The following is a description of a gene set: Any process that modulates the frequency, rate or extent of post-translational protein modification. Mouse Gene Set: GOBP_REGULATION_OF_POST_TRANSLATIONAL_PROTEIN_MODIFICATION species: Mus musculus, and this is the list of marker genes: Caml, Otud4, Birc7, Nxn, Herpud1, Rpl5, Tspyl5, Ube2v1, Trib2, Rnf180, Ube2n, Mtbp, Atg7, Akt1, Isg15, Bex1, Nod2, Egr1, Arnt, Birc5, Ube2v2, Mastl, Cblb, Dtx3l, Cdc20, Cep78, Pabpn1l, Per2, Angpt1, Commd1, Itch, Amer1, Dcun1d2, Pink1, Bex3, Peli3, Wbp1l, Bmi1, Hif1a, Klhl40, Siah2, Rbx1 (NCBI Gene Id 80401), Bcl10, Nlrc3, Fbxo33, Psen2, Btrc, Hsp90ab1, P3h1, Ube3a, Ubb, Rassf5, Paxip1, Rpl11, Arrdc4, Tspo, Topors, Usp4, Septin4, Sprtn, Hamp, Epm2a, Limk1, Kdm1a, Cav1, Trib1, Trim44, Atg5, Mycbp2, Tgfbr1, Ppia, Ubqln1 (NCBI Gene Id 97856), Prkcg, Dysf, Rwdd3, Skp2, Psen1, Mapk9, Dcun1d5, Parp10, Pinx1, Sae1, Dnaja3, N4bp1, Sumo2 (small ubiquitin-like modifier 2), Derl1, Aimp2, Inava, Fam107a, Ngf, Vcp, Sh3rf2, Ube2s, Phf23, Xiap, Hsp90aa1, Rassf1, Chfr, Adgrb1, Zc3h12a, Plk1, Gps2, Cep63, Rps3, Hspbp1, Wdr48, Gsk3a, Vps28, Sash1, Plaa, Ndfip1, Pias4 (protein inhibitor of activated STAT 4), Mapk8, Ndfip2 (NCBI Gene Id 77152), Spsb4, Nsmce3, Rbx1-ps (NCBI Gene Id 100046417), Gnl3 (NCBI Gene Id 30877), Tes3-ps, Fgfr3, Ahrr, Dnajb2, Tank, Pias3, Hamp2, Wnk1, Fbxw7, Sumf2, Birc2, Nop53 (NCBI Gene Id 98700), Smad7, Npm1, Axin1, Marchf7, Ubxn2a, Rchy1, Ripk2, Ube2b, Nhlrc1, Gtpbp4, Pdcd6, Daxx, Arrb1, Mul1, Fancm, Fbxo4, Psmd10, Cul3, Tollip, Rasd2, Gbp4, Ticam1, Fzr1, Ptpn22, Svbp, Bex4, Washc1, Mad2l1, Dcun1d1, Pef1, Dnaja1, Tbc1d7, Minar1, Hmg20b, Hspa1b, Fbxo2, Cdkn2a, Gsk3b, Lrrk2, Cdk5, Rpl23, Foxf2, Ctnnb1, Pten, Cdk5rap3, Chp1, Skp1 (NCBI Gene Id 76591), Ube2d1, Prmt3, Senp2, Ogt, Uba2, Usp44, Tcf25, Mad2l2, Sphk1, Flcn, Ube2l3, Hdac3 (NCBI Gene Id 15183), Ivns1abp, Capn3, Dcun1d4, Trim21, Epas1, Peli1, Trib3, Cdc14b, Rps2, Ddx3x, U2af2, Nscme3l, Mta1, Pttg1ip, Rela, Ttc36, Huwe1, Abca2, Rnf40, Cops9, Bag2, Sirt7, Cry1, Arrdc3, Sqstm1, Prkce, Crtap, Cd300ld3, Prkn, Fyn, Arrb2, Nmi, Wfs1, Spry2, Ufl1, Prickle1, D1Pas1, Tnip1, Pias1, Gabarap, Abl1, Gnl3l, Dcun1d3, Rnf111, Fanci, Hspa5, Birc3, Spopl, Sox4, Ubxn1, Ube2srt, Hdac8, Hdac4, Mtor, Laptm5, Fscb, Mapk15, Tnfaip3, Traf7, Stub1 (STIP1 homology and U-Box containing protein 1), Gclc, Park7, Bag5, Rps7, Hmg20a, Fbxo5, Tm9sf5, Bex2